Given this list of marker genes Gm14391, H2bc22, H3c2, H2ac23, Gps2, H4c14, Kdm6a, Zfp982, H2ac24, Zfp324, Zfp994 (NCBI Gene Id 240038), H4c1, Polr1g, Rbbp7, Smarca5, H2bc15, Tbp, H2ac11, H2bc11 (H2B clustered histone 11), Zfp119b, Zfp758, Zfp874b, H4c3, Ezh2, Zfp991, H2ac15, H2ac12, Zfp946, H2bc12, H2ac8, H4c4, H2bc27, H2ac7, Hcfc2, Zfp872, H4c17, Polr1e, Zfp995, Rbbp4, Gm5141 (NCBI Gene Id 380850), Phf20l1, H3c13, Zfp942, H2bc1, Ercc6, H2bc13, H4c2, Zfp354a, Tada2a, Gm45871, Phf20, Setd1a, H2ac1, H2bc9, Dnmt3b, Sgf29, Zfp677, H2ac6, H3f3a, Ddx21, Ash2l, H4c11, H2bc3, H2ac10, Polr1h, Men1, H2az2, H4c9, H2ac19, Polr2e, Zfp947, H2ac13, H3c8, Gm14325, H2ac20, Zfp992, H4c12, Hcfc1, H3c11, H3c7, H4c8, Mybbp1a, Dnmt1 (DNA methyltransferase 1), Ezh1, Ncor2, Pparg, Zfp971, AU041133 (NCBI Gene Id 216177), Polr2f, H3c3, H3c15, H3c1, Polr2l, Gm4924, H3c6, H2bc7, Tdg, H2ax, Zfp383 (NCBI Gene Id 73729), H3c10, Zfp987, Zfp317, B020011L13Rik, Taf1d, Polr2k, Zfp934, Paxip1, Zfp141, Hdac3, Kansl1, H4c18, H2ac22, Tbl1x, Kmt2b (NCBI Gene Id 75410), Gm10033, Zfp989, H2bc8, Zfp943, Wdr82, Zfp990, AI987944, Ep300, Polr1c, H2ac4, H3c4, Kansl2, Zfp454, H4c6, Gm7072, here is a description of the gene set: electronically inferred by orthology from the curated human pathway Reactome Pathway: Epigenetic regulation of gene expression part of: Gene expression (Transcription) studied in species Mus musculus This event has been computationally inferred from an event that has been demonstrated in another species.<p>The inference is based on the homology mapping from PANTHER. Briefly, reactions for which all involved PhysicalEntities (in input, output and catalyst) have a mapped orthologue/paralogue (for complexes at least 75% of components must have a mapping) are inferred to the other species.